Given this list of marker genes Mcmdc2, Hsf2bp, Brip1, Brme1 (break repair meiotic recombinase recruitment factor 1), Terb2, Terb1, Majin, Rad51, Morc2b, Fancd2 (NCBI Gene Id 78247), Dmc1, Prdm9, Spo11, here is a description of the gene set: species: Mus musculus Mouse Gene Set: GOBP_DOUBLE_STRAND_BREAK_REPAIR_INVOLVED_IN_MEIOTIC_RECOMBINATION The repair of double-strand breaks in DNA via homologous and nonhomologous mechanisms to reform a continuous DNA helix that contributes to reciprocal meiotic recombination.